The following is a description of a gene set: Mouse Gene Set: MIR_8116 from publication Chen Y, Wang X (PMID 31504780) Genes predicted to be targets of miRBase v22 microRNA mmu_miR_8116 in miRDB v6.0 with MirTarget v4 prediction scores > 80 (high confidence targets). species: Mus musculus, and this is the list of marker genes: Dcaf11, Traf5, Cidea, Tmem150b, Ccdc89, Slitrk3 (SLIT and NTRK-like family, member 3), Enox2, Cux2, Ptprf, Mrps11, Ptchd1, Trex2, Osbpl6, Dazap2 (DAZ associated protein 2), Dpys, Rhox12, Slc22a15, Senp3, Phf8, Susd5, Abhd6